Given this list of marker genes TENM3, RRN3P1, RND1, STAT6, TENM3-AS1, NLE1, CPN2, TTC1, here is a description of the gene set: Human Gene Set: ZNF493_TARGET_GENES from publication Yevshin I, Sharipov R, Kolmykov S, Kondrakhin Y, Kolpakov F (PMID 30445619) Genes containing one or more binding sites for (ZNF493) in their promoter regions (TSS -1000,+100 bp) as identified by GTRD version 20.06 ChIP-seq harmonization. species: Homo sapiens